The following is a description of a gene set: The process of creating protein oligomers, compounds composed of a small number, usually between three and ten, of component monomers; protein oligomers may be composed of different or identical monomers. Oligomers may be formed by the polymerization of a number of monomers or the depolymerization of a large protein polymer. studied in species Mus musculus Mouse Gene Set: GOBP_PROTEIN_COMPLEX_OLIGOMERIZATION, and this is the list of marker genes: Mcur1, P2rx3, Micu1, Best1, Kctd1, Trpa1, Hprt1, Cldn1, Acaca, Vwa1, Otol1, Sgta, Kcnc4, Fus, Tmem120a, Farsa, Lrrc8d, Crtc1, Jmjd6, Kctd2, Ikzf4, Letm1, Aqp11, Krt10, Gls, Sgtb, Kcna7, Acacb, Kctd21, Twnk, Trp73, Hsd17b8, Nlrp1a, Kctd6, Usp16, Trpm7, Slc31a1, Znhit6, Alad, Rom1, Mcoln1, App, Gm12250, P2rx7, Trp63, Gbp5, Kctd12, Shkbp1, Kctd3, Kcng4, Kcnv2, Stoml2, Nudt21, Trpm2, Cpsf7, Gsdmd, Prnp, Oas1e, Vps35, Tifa (TRAF-interacting protein with forkhead-associated domain), Kctd8, Kcnd3, Rnf112, Mospd2, Acot13, Mapt, Rrm1, Card11, Kcna5, Syt1, Wdcp, Stk4, Lrrc8a, Hscb, Trpm4, Spast, Kcnj12, Cd2ap, Blm, Kcnd2, Kcna6, Kctd15, Bcl10, Kcnc3, Oas1g, Prph2, Kcnn4, Rbmxl1, Samd1, Farsb, Hsd17b10, Kcnb2, Polq, Kcna10, Oas1h, Atl1, Kcnc1, Zdhhc1, Rnf135, Pnpt1, Kcns1, Mlkl, Homer1, Kctd7, Prmt8, Oas1b, B2m, Glra3, Comp (NCBI Gene Id 12845), C9, Oas1c, Steap4, Lrrc8c, Hdac6, Snca (NCBI Gene Id 20617), Kctd19, Kctd10, Cpsf6, Appl2, Kctd13, Trp53, Crtc2, Trim72, Kctd16 (potassium channel tetramerisation domain containing 16), Cryz, Tgm2 (NCBI Gene Id 21817), Arc, Pdcd6ip, Itpr3 (inositol 1,4,5-triphosphate receptor 3), Vstm5, Ehd1, Kcnrg, Aldoa, Pycard, Kcnt1 (NCBI Gene Id 77377), Pex5, Trpm1, Scara5, Mip, Calhm3, Gnmt, Col6a1, Stk3, Mat1a, Kcng3, Shmt1, Basp1, Itln1, Mcu, Atl2, Nol3, Kcna4, Aldh1a3, Rrm2, Shmt2, Aldh1a2, Kcnc2, Cutc, Hcn1, Cby1, Kcns3, Mbl1, Osbpl2, Tk1, Iapp, Thg1l, Grin2b, Nlrp3, Rs1, Kcnb1, Kcnj2, Kcna3, Opa1, Snupn, Bok, Nlrc4, Cd247, Tmem120b, Ryr1, Kcns2, Kcnf1, Pkm, Trp53bp1, Col1a2, Apip, Prnd (prion like protein doppel), Sting1, Tdo2, Cd74, H2-M3, Kcnd1, Zbtb1, Dele1, Samhd1, Ms4a1, Mpp2, Trpv5, Lzts3, Me1 (malic enzyme 1, NADP(+)-dependent, cytosolic), Ugt2b1, Prmt1, Pkd2, Nacc2, Cep57, Ryr3, Yme1l1, Dnm1, Aqp2, Kcnv1, Kcna2, Peg10, Pxdn, Ripk2, Mat2a, Trpv1, Crtc3, Atl3, Chmp2a, Aqp5, Clybl, Evl, Cth, Mif, Ifih1, Card9, Hgsnat, Oas1f, Pkd2l1, Slc9a1, Ripor2, Golga2, Nlrp6, Grin1, Sycp1, Cyren, Kcna1, Slc1a2, Zfp746, Zc3h12a, Sod2, Prf1, Gsdma3, Aqp4, Cbr4, Ehd3, Upb1, Abca3, Ssbp1, Oas1a, Sub1, Oxa1l, Trim65, Calhm1, Fkrp, Tmem70, Adcy8, Kctd11, Vasp, Trpv6, Ect2 (ect2 oncogene), Alox5ap, Dnm1l, Aldh9a1, Ugt1a1, Ugdh, Elavl1, Krt1, Kctd5, Ninj1, Kctd9 (potassium channel tetramerisation domain containing 9), Zfp777, G3bp2, Oas1d, Chp1, Als2, Ski, Slc1a5, Itpr1, Trpm6, Nlrp1b, Bend3, Gria3, Isg15, Tnfaip1, Mavs, Ehd4, Kcng1 (potassium voltage-gated channel, subfamily G, member 1), Gria2, Kctd4, Sigmar1, Pkd1